The following is a description of a gene set: part of: Gap junction degradation Reactome Pathway: Formation of annular gap junctions This event has been computationally inferred from an event that has been demonstrated in another species.<p>The inference is based on the homology mapping from PANTHER. Briefly, reactions for which all involved PhysicalEntities (in input, output and catalyst) have a mapped orthologue/paralogue (for complexes at least 75% of components must have a mapping) are inferred to the other species. electronically inferred by orthology from the curated human pathway studied in species Mus musculus, and this is the list of marker genes: Dnm2, Cltb, Ap2m1, Gja1